The following is a description of a gene set: Human Gene Set: GOCC_ENDOSOME A vacuole to which materials ingested by endocytosis are delivered. species: Homo sapiens, and this is the list of marker genes: TMEM108, ARHGAP26, LY96, AQP4, PRKCI, DERL1, NISCH, EHD2, ABHD17C, MVB12A, RNF128 (NCBI Gene Id 79589), LITAFD, MYO1B, STX7, KCNK1, IFNAR1, CACNG7, APH1A, NMNAT2, RAP1A, CD164 (NCBI Gene Id 8763), GOLIM4, SH3GL1, SLC11A1, OCIAD1, UVRAG, SERPINB1, BDKRB2, NDFIP1, PSENEN, DNAJC13, TMEM106B, PACSIN1, CHMP4BP1, GALNTL5, RAB4A, SLC30A4, RAB37, MAP1LC3A, NEURL1B, ATP6V1D, CLCN4, SLC1A1, MTMR4, ATP6V0E2, FSHR, DDIT3, PLA2G5, CD1A (CD1a molecule), DYNC1LI1, FLT3, ATP6AP1, TM9SF4, SGK3, STAMBP, HPS5, RAB24, MKLN1, CRHR1, KIF13A (NCBI Gene Id 63971), WDR48, ALS2, RFFL, ARRDC4, PLD4, ACKR4, CCDC154, CRHBP, TFRC, RAB7B, VPS13C, TCIRG1, PANK1, HLA-DRA (NCBI Gene Id 7930), ARAP1, RAB40A, MFSD12, AVL9, CAV1, FOLR1, SH3GL2, LMTK2, RAB5C, ELAPOR1, HLA-DMA, LRRK2, HDAC6, VPS37A, CREG1, VPS33B, RAB5A, CARMIL1, ASAH1, EZR, VPS8, ATP6V0A1, STMN2, HPS3, RAB27B, TBC1D3, TRIM3 (NCBI Gene Id 10612), SNX20, GPR107, GIGYF2, ATP6V1E1, JAK3, CHMP1B, ATP6V0B, FLOT2, SYT3, MCOLN2, EPHB1, SIGLEC1, PACSIN3, F8A1, VPS41, GPR61, MCOLN3, PTPN1, IRAK4, RAB3C, MREG, CLTC, CHMP7, TGOLN2, EXOC8, PLEKHJ1, TMEM30A, RAB26, RHOBTB2, DERL2, CORO1C, SCAMP2, RAB12, VPS18, F2RL1, UBE2D3, RAB11FIP3, WDR81, DYNC1LI2, TNF (NCBI Gene Id 7124), RUBCN, VPS16, WASHC5, CCDC22, WASH3P, RHOA, RAB38, NME1, SNX5, TTPA, LEPROT (leptin receptor overlapping transcript), PI4K2A, SLC9A5 (solute carrier family 9 member A5, NCBI Gene Id 6553), AVPR1A, AP1M1, MMP14, HLA-E, ADAM30, CARMIL2, WDFY2, SLC31A1, CD274, PDLIM4, AP3B1, RAB29, WASHC2C, RAB7A, CD14, ARC, ASTN1, RAP2C, GIT1, AP1S1, CDK2, FCGRT, AP2A1, STX12, HAS3, ARHGAP44, SNX18, RAB35, NCL, VPS51, RAP2A, PLEKHB2, GAPVD1, TBC1D12, TNK2, SLC38A9, PICALM (phosphatidylinositol binding clathrin assembly protein), RUFY4, VPS37C, APOA5, PARM1, SLC5A7, ATP9B, TAB3, ARPC2, NIPA2, NAPSA, HYAL3, NRP1, SLC26A7, HLA-DPB1, SPAAR, ANXA6, WDR44, MCOLN1 (NCBI Gene Id 57192), BACE2, AGAP2, TMEM63B, RABEPK, APOC3 (apolipoprotein C3), APOB, MYD88, ABHD17A, FCGR1BP, AMOTL2, MVB12B, EPHA8, RAB40AL, PLA2G4B, NUMB, TUBGCP4, OCA2, CLEC16A, DIAPH2, RNASEK, TMEM163, JAK1 (Janus kinase 1), SNX31, TMEM9, CD1E, ZFYVE16, NTRK2, TLR9, DENND2B, WIPF3 (WAS/WASL interacting protein family member 3), TUBG1, DNM2, GPR135, TOM1L1, CD68, HLA-F, SNX19, BLTP3B, RABGAP1L, EHBP1L1, FCMR, SNX27, SLC39A4, ITSN1, CD1C, MAP2K1, AQP2, RNF149, ABCC5, HLA-DQB1, TRAPPC10, TLR3, TAB1, APOA4, ZDHHC1, ABHD17B, RAB11A, DIAPH3 (NCBI Gene Id 81624), GIMAP5, VPS26C (NCBI Gene Id 10311), MMGT1, AGAP1 (NCBI Gene Id 22851), VAMP3, UNC13D, OR2A4, CTSS, ABCB6, HGS (NCBI Gene Id 9146), SFTPA2, PTP4A3, SNX6, CHMP4C, TMEM59, GP2, TPT1, APOE (NCBI Gene Id 99), SNX17, EHD1, TBCK, AGER, MIB2, AP2B1, PLD3, TRIM27, LDLRAD4, DNER, CTSL, WNT3A, TMEM45B, PIP4P2, CLEC18A, SORCS2, VPS50, SCAMP1, LAMP2, RAPGEF2, PGA5, ATP7B, WASHC4, ZFYVE28, HLA-A, YKT6, IL2RB, SFTPB, ABCG1, SLC30A2, SLC9A9, CLN6, PKN1, VPS28, VPS25, MGRN1, SRC, PDCD6IP, THSD1, SNX12, IL15RA, TLR8 (NCBI Gene Id 92553), IL15, RAB40B, LGMN, EPS15, NDRG1, STX4, RAB9A, FCHSD1, SCARB2, PLEKHF1, SPPL2B, GRB2, RFTN1, CHMP4A, HLA-DMB, HLA-DRB4, SLC6A9, SDF4, PHETA2, AP3B2, KCNK6 (NCBI Gene Id 9424), ACKR2, ZMPSTE24, SPG21, HLA-DQB2, KIR2DL4, SLC30A10, ATP9A, GRAP2, NGFR, F8A3, PRKCZ (NCBI Gene Id 5590), PIK3C3, SNX25, PML, TGFBRAP1, RET, B2M, ATP11A, PRL, RILP, ATP6V0D2, SLC31A2, CHMP3, PLD1, RD3, HSPD1, RUSC1, CACFD1, CCZ1B, FERRY3, PPP1R21 (NCBI Gene Id 129285), VPS11, GH1, LAMP1, APP, SNX14, LAMTOR4 (late endosomal/lysosomal adaptor, MAPK and MTOR activator 4), CHMP1A, MICALL2, FIG4, ATP11C, ANGPTL3, USP8, VPS29, RAB1A, RAB11FIP4, MAP2K2, DOP1B, CD207, F2R, NSG1, LRP2, MYO6, PRDX3, NOTCH1, SNX11, APPL1, EGFR, LAMP3, SNX3, ARRDC5, UBE2A, AP1G1, TRAPPC5, AP1G2, RBSN, UBAP1L, DTNBP1 (NCBI Gene Id 84062), ABCA1, RNF167, LRPAP1, MR1 (NCBI Gene Id 3140), ATP6V0C, VTA1, MME, RNF144A (NCBI Gene Id 9781), ARHGAP32, KIFC1, NCDN, AP4B1, ATP6V1A, SLA, SCAMP5, SIAH2, NEURL3, AP3M2, ATP13A3, FGFR4, CDKN1B, RHOB, RAB23, MYCBPAP, PLEKHM1, PDIA3, CNTNAP2, CUBN, ACAP1 (NCBI Gene Id 9744), ZDHHC11, SLC9A8, RNF148, ATP6V0D1, SLC34A1, RAB3B, SMIM22, SAMD9L, CFTR, PLIN3, CCZ1, SLC66A2, VPS37B, TASL, ECPAS, STOML1, VPS35L, HMGB1, MITD1, CD1D, PGA3, VPS26B, AP4E1, HLA-H, CLVS2, HLA-DOB, IL12B, UBXN6, SLC46A1, SLC5A1, VAMP7, RAB27A, CBLIF, CD4, ABCB11 (NCBI Gene Id 8647), STS, PLEKHF2, SQSTM1, C8orf44-SGK3, SLC9B2, GRIA1, ACKR3, TMEM192, PTP4A2, SNX13, STAM, PIP5K1C, LPAR1, SLA2, LAPTM4B, OCRL, GPR15, EPHA3, PI4K2B, ACAP2, STAMBPL1, ULK1, CDH1, IL2RG, GFRA1, ATP1A2 (NCBI Gene Id 93186), RAB11FIP2, OSBPL9, AKAP5, SMPD1, CSH1, CHMP2B, AP3S1 (NCBI Gene Id 89412), VPS39, MMD, TSPAN15, ADRB1, TRAPPC3, RNF133, IRAK1, RAB11FIP5, SMO, SLC2A4, PGA4, HLA-DQA1, YIPF2, PSAP, ATG9A, IRF7, SBF2, CLVS1, PTPRN, VTI1A, SPHK1 (NCBI Gene Id 8877), FGD5, RUFY1, TBC1D14, NF2, INPP5B, SLC30A3, HLA-DRB1, CHMP4B, RAP1GAP, KIAA0319, CLSTN1, CLIP3, GPR65, IRAK2, FURIN, NGF, SLC6A4, CTSB, GATD1, ZC3HAV1, GRIPAP1, PSEN1, VPS53, CD8B, TRAPPC6B, TRAF3, AVPR1B, NDFIP2, AP1S3, TOLLIP, CTSE, ANKRD13A, ZFYVE27, TOM1L2, WASHC3, F8A2, ABCA7, VOPP1, BLOC1S1, PHETA1, STEAP1, DENND6B, AP5Z1, VPS52, CD63, SFTPC, ARFGEF2, UBAP1, MELTF, PRKAR1A, ATP11B, GPNMB, SLC15A3, CHMP6, TM9SF2, TMEM184A, HLA-G, LLGL1, DIO3, RAB9B, MARCHF8, LRP6, IFITM2 (interferon induced transmembrane protein 2), CDIP1, CTSK, SFTPD, WASHC1, HSD17B6, MYO5A, OR51E2, TRAPPC14, TRAK2, TRAPPC2, VCAM1 (NCBI Gene Id 7412), RMC1, RAB10, INPP4A, RHOV, CD22 (CD22 molecule), ACP3, MON2, MLC1, RABEP1, RAPGEF1, HLA-DPA1, GRIN2B, LHCGR, ADRB2, GRB14, VAC14, ATP6V0A4, MICALL1, TRAPPC4, GOLPH3, INPP5F, BACE1, CYBA, RAP2B, NEU3, RAB5B, TJAP1, WDFY4, USP10, PRF1, FKBP15, TRAPPC13, CCDC120, ARL8A, SLC2A13, ANKRD50, ZFYVE9, CD300LG, TMEM63A, MARCHF2, RAB11FIP1, PIP4P1, SLC11A2, CLEC18C, FZD5, OSBPL6, LAMTOR1, DYSF, LDLR (NCBI Gene Id 3949), LITAF, PTPN2, OPRM1, SNX16, CX3CR1, PLA2G4E, LAMTOR3, MAPK1, VAMP5, RAB13, ABCG4, RAB8A, ADCYAP1R1, AOC3, APPL2, AP5S1, EPN1, TRAPPC2B, TMUB1, RAB33B, STX6, LDLRAP1, BOK, BSG, TBC1D2B, HLA-B, FFAR4 (NCBI Gene Id 353126), UBA52, CLEC10A, STARD3NL, NOX1, DBNL, LTF, EEA1, ANKRD27, RIPK1, PLA2G3, WASHC2A, SNX30, RHOD, AP3M1, SLC48A1, TLR4, SCYL2, MYO1D, APOA2, STEAP3, TMEM175, PDCD6, MYO5B, SLC9A6, PIK3R4, BIN1, HLA-DRB3, RAB25, CLIP1, ENTHD1, CD74, BLTP3A, TMBIM1, YIPF1, APOA1, ARF6, FZD7, CCDC93, VPS13A, DKK1, MAPK3, SNX32, RAB31, COMMD1, RAB33A, NPC1, CLINT1, CTSD, TAB2, TMEM9B, TMEM230, SYT5, SNX21, CLCN5, WASF2, ANKRD13B, TOM1, MTMR2, RNF32, BIRC6, PSEN2, HLA-DRB5, GNPNAT1, ATP13A4, PRLR, CD2AP, CYB561A3, RABEP2, CC2D1B, SLC46A2, PRKCD, IL12A, GPC1 (NCBI Gene Id 2817), RAB17, SPPL2A, ATP6V1F, SUN2, HLA-DQA2, GGA2, TMEM25, RAB20, ATP8A2, VPS35, CLTA, APBB2, GPER1, AP5B1, STEAP1B, LRP1, FCGR1A, MON1B, ANKFY1, AP2S1, GPR62, RUFY3, APH1B, CHMP5, ARHGAP10, KDR, ARRDC3, ANKRD13D, AP4M1, SYNDIG1, C1orf210, ATP10B, AP2M1 (adaptor related protein complex 2 subunit mu 1), VAMP4, CPNE6, RHOBTB1, GPR161 (NCBI Gene Id 23432), TMEM150B, TSG101, EIPR1, VPS13B, LRAT, IRGM, MRC1, UBB, FLOT1, KIF16B, OCIAD2, NCSTN, CALY, ITCH, M6PR (mannose-6-phosphate receptor, cation dependent), APOC2, RABGEF1, RAB32, RELCH, SLC6A5, ITM2B, MARCHF1, ITGB1, TBC1D16, SORL1, TPP1, SH3GL3 (SH3 domain containing GRB2 like 3, endophilin A3), ANTXR2, ENTREP1, HLA-DOA, VPS4A, CXCR4, EXPH5, KIDINS220, MAGI2 (NCBI Gene Id 9863), STEAP2, MAP3K7, STARD3, DTX3L, CLCN3, ARL8B, GGA3, ZNRF2, USP6, SLC9A7, TMEM127, PHB1, STEAP4, LAMTOR5, PMEL, FGD2, TF, PLEKHM2, VTI1B, REP15, AP4S1 (NCBI Gene Id 11154), ATP13A2 (NCBI Gene Id 63919), HTT (NCBI Gene Id 3064), HAP1, UEVLD, ZFYVE21, SNX7, RAB14, CCR5, ATP6V1H, FYCO1, RUFY2, MFSD8, LZTR1, RNF112, TNFAIP1, RHOU, TICAM1, CYTIP, AP3S2, ASTN2, CC2D1A, ZDHHC2, S1PR1, MAPKAP1, SCAMP4, RCC2, RPS27A, FCHSD2, DAGLA, LIPG, DOP1A, ATP13A5, ENTR1, PTP4A1, CLEC18B, ACE, RAN, TRAK1, KCNH1, EHBP1, NBR1, ABCA3, STING1, ANXA8, SYT11, BECN1, ARHGAP1, WDR91, TRAPPC2L, CHID1 (NCBI Gene Id 66005), RASSF9, OSBPL1A, TUBA1A, LAMP5, CRYZL1, NAPEPLD (N-acyl phosphatidylethanolamine phospholipase D), PIKFYVE (phosphoinositide kinase, FYVE-type zinc finger containing), SLC35D3, PACSIN2, NIPA1, SNX8, NTRK1, MON1A, VPS33A (VPS33A core subunit of CORVET and HOPS complexes), TLR7, GH2, ANK2, CLCN6, DENND6A, SNX2 (sorting nexin 2), KCNQ1, STAM2, PTPN23, SPAST, INSR, CST7 (NCBI Gene Id 8530), BET1L, TICAM2, RAB11B, PI4KB, ABHD6, ABCB9, WLS, SLC36A2, RNF11, EHD4, SORT1, ANXA1, UBA1, SNX1, CALCRL (NCBI Gene Id 10203), AP1B1, BAIAP3, HLA-C (major histocompatibility complex, class I, C), RASGEF1B, UBR4, CD1B, RAB40C, CPTP, PCSK9 (NCBI Gene Id 50983), VPS4B, MARCHF3, JAK2, WIPI1, PRAF2, KCMF1, ATP6V0A2 (ATPase H+ transporting V0 subunit a2), SYTL4, AMN, MICAL1, RAB8B, RAB4B, PMEPA1 (NCBI Gene Id 56937), BLOC1S6, MTM1, WDFY1, TMEM165, SLC39A14, EHD3, C9orf72, ERBB2, HAVCR2, TBC1D5, VPS37D (NCBI Gene Id 171020), NEDD4L, IGF2R (NCBI Gene Id 3482), RAB3A, SCOC, KREMEN2, CHMP2A, WDR83, ZP2, CLN3, RAC1, RAB3D, IFITM3, ZNRF1, TBC1D17, LAMTOR2, RAB15, SNX10, SLC9A3, NCF4, TYRP1, TRAF6, ANXA2, HFE, TNIK, PLPP2, FLT1, AP3D1, SIAH1, SFTPA1, AKT2, STX8, ATP6AP2, CD79A, EPN3, MAGEL2, CLTCL1, RIN3, MCTP1 (multiple C2 and transmembrane domain containing 1), GGA1, ANTXR1, DGKH, ACKR1, ZFYVE26, TPCN1, OSBPL11, TGFBR1, ABCA2, SCAMP3, DCSTAMP, BST2, CORO1A, SNF8, HPS6, GOSR2, ANP32E, TRAPPC1, EPHA4, CTNS, LAPTM4A, UNC93B1, RNF13, ATP7A, SNX4, MBL2, ATP6V0E1, ATG16L1, TGFB2, VPS36, INS, SLC26A9, AP1AR, PRSS16, AVPR2, CTSH, RPS6KC1, PRKAR1B, NSG2, FYN, DENND10, WASH6P, VIPAS39, TPCN2, LNPEP, VPS45, GRN, AP1S2, DYNC1I1, VPS26A, UBC, TRAPPC9, CMTM6, OPTN, DGKQ, ABCA5, HTR4, LEPROTL1, ATG9B, PLEKHA3, RAB21, ECE1, SLC15A4, ADRA2C, AP2A2, EPN2, RCSD1, CCDC115, SLC29A3, ST8SIA2, SLC17A8, SPNS2, AP5M1, RAB22A, VAMP8